Given this list of marker genes Fos, Ier2, Zfp36, Btg2, Dusp1, Jun, Atf3, Pmaip1, Fosb, H3f3b, here is a description of the gene set: Cytokines mediate cell-cell communication in the immune system and represent important therapeutic targets. A myriad of studies have highlighted their central role in immune function, yet we lack a global view of the cellular responses of each immune cell type to each cytokine. To address this gap, the authors created the Immune Dictionary, a compendium of single-cell transcriptomic profiles of more than 17 immune cell types in response to each of 86 cytokines (>1,400 cytokine-cell type combinations) in mouse lymph nodes in vivo. A cytokine-centric view of the dictionary revealed that most cytokines induce highly cell-type-specific responses. For example, the inflammatory cytokine interleukin-1β induces distinct gene programmes in almost every cell type. A cell-type-centric view of the dictionary identified more than 66 cytokine-driven cellular polarization states across immune cell types, including previously uncharacterized states such as an interleukin-18-induced polyfunctional natural killer cell state. Genes negatively differentially expressed in cell type: cDC2 (conventional dendritic cell type 2) upon treatment with cytokine: TPO in mouse lymph nodes in vivo. species: Mus musculus from publication Cui A, Huang T, Li S, Ma A, Pérez JL, Sander C, Keskin DB, Wu CJ, Fraenkel E, Hacohen N (PMID 38057668) Mouse Gene Set: CUI_CDC2_TPO_RESPONSE_DN